The following is a description of a gene set: species: Homo sapiens Human Gene Set: chr15q22, and this is the list of marker genes: TPM1, MIR4511, CLPX, RORA, RNA5SP397, RAB11A, VPS13C, ZWILCH, SNX22, SNORD18A, GTF2A2, ENSG00000259351, SNORD16, ATP5MFP6, GOLGA2P11, RNA5SP396, IGDCC4, RPL21P114, HERC1, PPIB, CCNB2, CSNK1G1, SMASR, MIR4512, SNORD18B, LDHAL6B, RPL36AP44, SMAD3-DT, C2CD4A, SPG21, SCARNA14, FBXL22, MIR1272, MESTP2, ANXA2, TLN2, SMAD6, SLC24A1, SMAD3-AS1, HMGN1P26, CA12, INTS14, CILP, NMNAT1P5, SNORD18C, KBTBD13, RBPMS2, MTFMT, ICE2, RPL21P15, MIR2116, LACTB, FOXB1, SNORA24B, HMGN2P47, GAPDHP61, RNU5A-1, MIR422A, CYCSP38, RPL21P14, DAPK2, PIF1, MGC15885, NSA2P4, TPM1-AS, IGDCC3, DPP8, RNF111, ZNF609, C2CD4B, DENND4A, ENSG00000305721, PARP16, RNU6-686P, USP3, RNU6-549P, MIR8067, LINC01169, SMAD3, RORA-AS2, MEGF11, RPL9P25, RNU5B-1, RPL21P113, ENSG00000259697 (NCBI Gene Id 255177), OAZ2, RNU6-19P, ENSG00000259530, LINC02349, RNU6-212P, DIS3L, DIS3L-AS1, SNORD13E, TRIP4, SLC51B (NCBI Gene Id 123264), RNU4-80P, CIAO2A, RPL35AP32, RPS27L, MIR4311, LINC02568, RPL7AP75, RASL12 (RAS like family 12), SLTM, ZNF444P1, NPM1P47, ANKDD1A, APH1B, FAM81A, SNX1, USP3-AS1, PCLAF, HNRNPA1P44, MYO1E, HACD3, MIR190A, SNAPC5, TIPIN, RORA-AS1, RAB8B, MIR6085, VPS13C-DT (NCBI Gene Id 101928907), PLEKHO2, RPS3AP6, RPL4, GCNT3, LCTL, PIGHP1, UBAP1L, RPL21P117, BNIP2, PDCD7 (NCBI Gene Id 10081), MAP2K1